Given this list of marker genes TRIM32 (tripartite motif containing 32), TRIM35, CHMP3, TRIM26, TRIM25, PML, MID2, MARCHF2, TRIM21, TRIM28, TRIM8 (NCBI Gene Id 81603), TRIM5, TRIM13, VAPB, TRIM15 (tripartite motif containing 15), TRIM27, TRIM11, here is a description of the gene set: species: Homo sapiens A process in which a host organism stops, prevents or reduces the frequency, rate or extent of the release of a virus with which it is infected, from its cells. Human Gene Set: GOBP_SUPPRESSION_OF_VIRAL_RELEASE_BY_HOST